The following is a description of a gene set: species: Mus musculus Mouse Gene Set: GOBP_MEMBRANE_ORGANIZATION A process which results in the assembly, arrangement of constituent parts, or disassembly of a membrane. A membrane is a double layer of lipid molecules that encloses all cells, and, in eukaryotes, many organelles; may be a single or double lipid bilayer; also includes associated proteins., and this is the list of marker genes: Rab39, Serinc2, Slc25a5, Spire1, Immt (inner membrane protein, mitochondrial), Mtss1, Akt1, Sec23a, Rtn4, Timm10, Rims2, Emc8, Rimbp2, Clu, Rer1, Naif1, Eqtn, Syngr2, Cert1, Plekha8, Atp8b2, Plaat3, Trappc1, Clec7a, Tor1aip2 (torsin A interacting protein 2), Samm50, Ppm1k, Scap, Dnm1l, Marco, Rhot1, Nup93, Pparg, AU040320, Chmp2b, Cav3, Trim72, Vcpip1, Crkl, Megf10, Lmnb1, Atp8b1, Aif1, Itgam, Oxa1l, Cd9, Syt3, Erc2, Emc9, Sec23b, Chmp1b, Rab7, Lyzl6, Clec2i, C2cd2l, Bnip3, Large1, Rab3a, Rab1a, Vamp8, Ccdc88a, Gltp, Tafazzin, Prf1, Nrxn1, Yipf4, Ier3, Pltp, Atp10a, Ptprc, Josd1, Mtch1, Cd2ap, Cplx4, Lrrtm4, Sec24d, Nrcam, Tram1, Siglece, Ank2, Csrp3, Col5a1, Fasl, Atp11c, Fat4, Spaca6, Cul3, Crk, Lbp, Nlgn3, Cstad, Stx1b, Acaa2, Trem2, Slc4a1, Rph3a, Arf1 (NCBI Gene Id 11840), Pdcd6ip, Ano4, Pla2g5, Hip1r, Dppa1, Sgta, Stx8, Trpc5, Stx19, Plscr2, Get3, Xkr4, Fcho2 (NCBI Gene Id 218503), Reep1, Pitpnb, Grip2, Abca1, Ist1, Gldn (NCBI Gene Id 235379), Znrf1, Vps11, Pals1, Exoc1, Rilpl1, Stxbp6, Ssh1, Ehd2, Abca4, Mul1, Moap1, Rhot2, Npc1, Frey1, Shisa6, Gas6, Gzmb, Mitd1, Abca12, Itgb1, Ano3 (NCBI Gene Id 99077), Pmaip1, Ncln (nicalin), Mia3, Nlgn2, Abcb1b, Grik5, Atp5if1, Kcnip2, Exoc4, Triap1 (TP53 regulated inhibitor of apoptosis 1), Sirpa, Gosr1, Gimap3, Sec24c, Sar1a, Vps39, Sorbs2, Mapk15, Tom1, Cntnap2, Ap3b1, Elmo1, Cript, Wdr83os, Glrb, Izumo1r, Golph3, Sar1b, Itgb2, Cavin2, Abca2 (NCBI Gene Id 98943), Mymk, Ap3s1, Psap, Abcd2, Lemd3, Afg3l1, Mfn2, Tomm70a, Tmco1, Tomm40, Sytl4 (synaptotagmin-like 4), Chmp4c, Samd9l, Akt2, Itga3, Gnai3, Epn1, Timm22, Tmeff2, Gba2, Osbpl5, Pdcd5, Aurkb, Dysf, Stx12, Plcg2, Bok, Atg2b, Syt9, Get4, Atp8b4, Cdk1, Fer1l6, Vps4b, Emd, Hspa8, Vps4a, Arhgap25, Cideb, Pitpnc1, Adam8, Sh3tc2, Treml4, Farp1, Cplx3, Stx1a, Rilp, Atp8b3, Rab4b (NCBI Gene Id 75702), Agrn, Akap5, Zdhhc2, Sec13, Cptp, Ppif, Tram2, Cln3, Pikfyve, Clip1, Yjefn3, Pex5, Spata46, Spg11, Nomo1, Dctn1, Arl6ip1, Wnk1 (NCBI Gene Id 406236), Romo1, Trappc6a, Vamp9, Atp11a, Bet1l, Tor1b, Dcst1, Tgfbrap1, Reep3, C3, Atp10b, Trmt10b (NCBI Gene Id 69934), Ap3b2, Cdc42, Chchd10, Pdcd6, Ano7, Timd5, Snx9, Becn1, Sclt1, Syt2, Pitpna, Vti1a, Mtch2, Lemd2, Stxbp1, Hyal2, Rab31, Mtmr4, Pdcd5-ps, Pitpnm2, Apool, Snap47, Fer1l5, Fa2h, Gimap5, Tmem14a, Tmcc1, Cidec, Pla2g4a, Zmynd8, Tpst2, Spart, Fxn, Arl8b, Adck1, Ap3d1, Atp2c1, Dmpk, Rab5if, Cdh2, Micu1, Tmed10-ps, Tmem102, Emc7, Trappc11, Osbpl2, Trappc10, Xkr8, Dnm1, Myo18a, Akap8l, Dhcr24, Timd2, Get1, Vti1b, Plscr3, Ano5, Syt13, Mafb, Sptb, Cd24a, Bax, Ighg1 (NCBI Gene Id 16017), Alox15, Stx16, Spaca5, Sh3bp1, Lmnb2, Bltp3b, Trappc2l, Ager, Trappc5, Gphn, Mx2, Ar, Smpd1, Gsdmd, P2rx7, Chchd6, Sppl2c, Tmem201, Bcl2l1, Lhfpl4, Trappc9, Snx18, Gdnf, Ndel1 (nudE neurodevelopment protein 1 like 1), Stap1, Mttp, Rims1, Emp2, Zmpste24, Exoc7 (exocyst complex component 7), Abcc1, Epb41l3, Stx18, Arhgap12, Arfgap3, Vps33b, Rftn1, Sh3gl2, Tbc1d20, Syt4, Sphk1, Sgca, Pten, F2rl1, Gnpat, Ptprd, Snap25 (synaptosomal-associated protein 25), Snap29, Etnppl, Gulp1, Ank3 (ankyrin 3, epithelial), Klhl12 (kelch-like 12), Ankle2, Cntn2, Bcl2, Cd36, Asap1, Dynlt1c, Colq (NCBI Gene Id 382864), Flot1, Plk1, Tmem30a, Trdn, Bnip1 (NCBI Gene Id 76517), Pip4k2b, Tmem126a, Micall2 (MICAL-like 2), Lrp5, S100a9, Sod1, Doc2g, 4930451I11Rik, Znrf2, Camk2a, Ap3s2, Vdac2, Hsp90aa1, Slc30a1, Tmem41b, Trappc6b, Snca, Timm13, Spg7, Rtp3, Rufy4, Prkn, Tsc2, Chmp1b2, Caml, Cplx1, Wasl, Arfgap2, Nsfl1c, Emc6, Stx2, Sgcg (sarcoglycan, gamma (dystrophin-associated glycoprotein)), Smurf1, Eya2, Gbf1, Abca3, Il1rapl1, Snx27, Pacsin3 (NCBI Gene Id 99363), Laptm5, Rab34, Scp2, Chmp2a, Uqcc3, Hdac3, Chchd3, Tmem147, Oma1, Ghitm, Mesd, Lpcat3, Tmem30c, Vapa, Bcs1l, Chmp6, Sec16a, Hgs, Fnta, Syt8, Iqgap1, Dynlt1b, Sgcd, Rufy1, Sgcz, Nfasc, Tor1aip1, Dlg4, Snx33, Lyzl4, Adam1a, Emc2, Rab7b, Slc12a1, Stx5a, Serinc3, Tlcd2, Cplane2, Alkbh4, Anxa1, Bin2 (bridging integrator 2), Col6a1, Fchsd2, Rtp1, Crb1, Pink1, Havcr1, Eea1, Mymx, Anxa7, Rab14, Cav2, Abcd1, Fchsd1, Sec31a (NCBI Gene Id 69162), Stx3, Sec31b, Timm29, Ptn, Slc25a46, Doc2a, Timm9, Yipf5, Nrxn2, Slc2a4, Rapsn, Nox1, Ubl4a, Fer1l4, Trappc3, Atg9b (autophagy related 9B), Ilk, Pacsin1, Bak1, Pip4k2a, Tram1l1, Hspa4, Degs1l, Lmna, Myrf, Hyal5, Gper1, Spaca3, Emc3, Gosr2 (NCBI Gene Id 97688), Snx3 (sorting nexin 3), Nectin2, Arv1, Pmp2, Tmed2, Pafah1b1, Brox, Kif20a, Dynlt1f, Bid, Trim9, Rft1, Prkci, Stx7, Shisa7, Stx4a, Plec, Atp10d, Dmkn, Kcnb1, Catsper1, Pitpnm1, Huwe1, Casp7, Dnajc11, Folr2, Chmp7, Dcst2, Gata2, Frrs1l, Nemp1, Shank3, Ephb2, Snapin, Prelid1, Exoc5, Plscr5, Sypl2, Snph, Azin2, Apoe, Atr, Cxcr4, Tmem33, Kcnn4, Fzd9, Bcl2l2, Letm1, Micos13, Baiap2, Coro1a, Atg2a, Micos10, Parp11, Atg9a, Dcstamp, Spast, Ykt6, Diaph3, Stat3, Plscr1l1, Dok7, Bin3 (NCBI Gene Id 80552), Ano6, Nup155, Cibar1, Tor1a, Alkbh7, Vamp4, Lrrc4, Surf4, Zfyve19, Reep2, Vav3, Sorbs1, Golph3l, Cav1, Gsk3a, Timd6, Prrt2, Folr1, Btbd8, Otof, Tardbp, Rtp2, Fcgr2b (Fc receptor, IgG, low affinity IIb), Dlg2, Cln8, Atf2, Baiap2l2, Ttpa, Abca7, Plscr1, Sun1, Timd4, Ugcg, Chmp4b, Arl6, Chrnb1, Syt1 (NCBI Gene Id 20979), Myc, Vamp2, Slc9a1 (NCBI Gene Id 20544), Myh10, Magi2, Sptbn4, Rubcnl (NCBI Gene Id 380917), Esyt1, Chmp5, Syt11, Syngr1, Nkd2, Emc10 (ER membrane protein complex subunit 10), Dnm3, Bloc1s2, Cox18, Grin3b, Trp53, Stx11, Snap23, Msr1, Tmem95, Mbp, Banf1, Picalm, Steep1, Tmem43, Xkr7, Izumo1, Nherf1, Fcgr3, Umod, C2cd5, Slc25a31, Adgrb1, Opa1 (NCBI Gene Id 74143), Atp8a1, Plekhm2, Cnp, Trappc12, Atg7, Tie1, Spam1, Rac1, Xrcc4, Ighg2b, Atp8b5, Hace1, Preb, Bcl2l11, Atl1, Slc35f6, Selenon, Tmem170, Thbs1, Chmp3, Hk2, Gltpd2, Cacna1b, Osbpl8, Fcer1g, Ndrg1, Nlgn1, Anxa2, Slc25a4, Bnip3l (BCL2/adenovirus E1B interacting protein 3-like), Pacsin2, Maip1, Grxcr1, Vapb, Exoc6, Vmp1, Reep5, Exoc6b, Fnbp1l, Cep55, Timm50, Slc66a2, Dynlt1a, Serinc5, Exoc8, Yipf7, Degs1, Bin1, Trarg1, Cit, Itga2, Naxe, Vamp1, Pmp22, Mal, Clcn2, Lpcat2, Atl2, Mpv17l, Ccdc47, Slc7a11, Myof, Tmem175, Whamm, Kif5b, Siva1, Bet1, Them4, Ctdnep1, Syt7, Agk, Etv5, Dnaja3, Vps41, Laptm4b, Atp9a, Cltrn, Cidea, Erc1, Plscr4 (NCBI Gene Id 235527), Stpg1, Sec61a1, Fsip1, Htr1a, Bag6, Exoc3, Atp13a2, Llcfc1, Slamf1, Ankfy1, Appl2, Prx, Casp1, Sh3glb1, Ubxn2b, Fcgr1, Xkr9, Sun2, Cplx2, Ano9, Coro1c, Ndufa13, Atp11b, Gsk3b, Ankrd27, Clcn3 (chloride channel, voltage-sensitive 3), A4galt, Myoc, Bloc1s6, Rilpl2, Ppt1, Tomm22, Ap3m2, Rph3al, Sec22b, Rab8a, Chmp1a, Stx6, Rab20, Tlcd1, Mtss2, Ap2m1, Lrch4, Clptm1l, Uvrag, Tnfaip8l3, Spire2, Dnm2, Reep4, Tmed10, Spesp1, Zfp13, Insig1, Trappc2, S100a10, Afg3l2, Spta1, Snap91, Lrp4, Emc1, Sox30 (NCBI Gene Id 278440, SRY (sex determining region Y)-box 30), Reln, Micall1, Mfsd2a, Gclc, Gsn, Doc2b, Cdan1, Ch25h, Mmgt1, Rhoa, Abcb4, Wdr54, Dock2, Nckap1l, Atp9b, Trappc13, Sh3glb2, Tmem30b, Stx17, Musk, Dlg1, Xkr6, Exoc2, Tgfb2, Baiap2l1, Glipr1l1, Syt5, Tmed9, Ubxn2a, Myh9, Bltp1, Emc4, Myadm, Abcb1a (NCBI Gene Id 64575), Sgcb, Chp1, Vamp3, Septin8, Mtfp1, Atp2a2, Sec24b, Ap1s2, Abcg1, Rtp4, Apoo, Des (NCBI Gene Id 13346), Nol3, Bad, Uso1, Cd300a, Pef1, Dbn1, Colec12, Sptbn1, Tbc1d4, Sec24a, Tmem11, Plekhm1, Chrdl1, Nlgn4l, Dvl1, Lat, Vps8, Atp8a2, Trappc4